The following is a description of a gene set: Glutaric aciduria Human Gene Set: HP_GLUTARIC_ACIDURIA species: Homo sapiens The concentration of glutaric acid in the urine, normalized for urine concentration, is above the upper limit of normal., and this is the list of marker genes: HMGCL, ETFB, ETFDH, ETFA, D2HGDH, SUGCT, GCDH